Given this list of marker genes PPM1H, CNOT4 (NCBI Gene Id 4850), ZNF329, NAA35, CLCA2, ZNF692, LTO1, GFI1, MFHAS1, COX6C, MRGPRF, WNT9A, RNF216, KRT2, RAP1GAP2, PCDHB10, GP1BB, PXYLP1, CCNJ, NT5DC1, ATL1, NFE2L2, PRPF8, SNX5, PRKAR1A, FAM241A, PUM1, NCK2, CHRNA3, NDST2 (NCBI Gene Id 8509), BBOX1, RAD21, C5orf63, CDK14, TWF2, MACIR, DUBR, NAA38, PARP16, SS18, NAPG, ZNF627, ITGAV, KBTBD8, ZNF571, GDPD3, SLC6A14, PCGF3, LUC7L3, CD200R1, HYCC1, TSEN34, PAPOLG, SLC12A5, CLCN4, SLC25A28, TNKS, CCDC71L, SPOP, MDM1, UHMK1, STK10, ALKBH2, POC1B, AMFR, TMEM184C, PCNT, GPC1, IK, BTBD10, EIF4ENIF1, MFN1, CMKLR1, CNRIP1, GPBP1L1, PTS, ABI1 (NCBI Gene Id 10006), CAPN2, NFATC1, RBL2, SERINC4, KHDRBS3, TMEM72, MRM2, FBXO28, BRD3, TSG101, BOD1, FAM114A2, ASB9, ARHGAP31, NFE2, SLC49A4, TBX21, ZBTB2, ZNF383, COG6, MGAM, ZEB2, METTL25B, PTTG1, UBE2R2, CASP7, CAMK2B, FHIP2A, MUTYH, MAIP1, ZRANB2, FAM20C, POLR3G, PKD1, TERF1, SLC39A13, ENTPD1, LRP6, ZBTB33, PCYOX1 (NCBI Gene Id 63081), RB1CC1, ANKHD1, ZFP90, PDCL, ARHGEF3, KANSL3, SNX18 (sorting nexin 18, NCBI Gene Id 112574), ZDHHC15, PHF1, NQO2, XPOT, SPIDR, CASP9, ACIN1, SPN, SLC30A1, ELAC1, NDRG3, ZNF394, ARHGAP30, ATXN1L, CYTH1, SOCS4, ZBTB4, DNAJA2, SNAP47, TMED2, ZNF322, ADSS1, EIF3G, POLD1, PATZ1, EP300, TMC6, TBCCD1, FBXO45, MYLIP, DENND2B, DDX20, ANAPC10, ILRUN, QPRT, BORCS7, TSC2, INPP4A, RBM22, ARSK, ITPA, PRDM1, USP1, FBXO3, KLRD1 (killer cell lectin like receptor D1), ZC3H4, PHYHIP, PUM2, TRIM3, ACYP1 (acylphosphatase 1), LSM5, EN2, VIRMA, UBAC1, STRIP1, UGDH, BFAR, PIP4P2, FUCA2 (alpha-L-fucosidase 2), CDC20B, WDR5B, SCN2B, PPM1D, ZNF251, ATP13A1, ANP32B, ZNF14, RPS6KA3, CALCOCO1, ACBD3, WDR86, TAF3, TIMP3, EXOC6B, here is a description of the gene set: Previous reports have defined three subsets of mouse NK cells on the basis of the expression of CD27 and CD11b. The developmental relationship between these subsets was unclear. To address this issue, we evaluated the overall proximity between mouse NK cell subsets defined by CD27 and CD11b expression using pangenomic gene expression profiling. The results suggest that CD27+CD11b-, CD27+CD11b+ and CD27-CD11b+ correspond to three different intermediates stages of NK cell development. from publication Chiossone L, Chaix J, Fuseri N, Roth C, Vivier E, Walzer T (PMID 19234143) Genes down-regulated in comparison of mature NK cells versus intermediate mature KN cells. Human Gene Set: GSE13229_MATURE_VS_INTMATURE_NKCELL_DN species: Homo sapiens